The following is a description of a gene set: from publication Chen Y, Wang X (PMID 31504780) Human Gene Set: MIR3184_3P species: Homo sapiens Genes predicted to be targets of miRBase v22 microRNA hsa-miR-3184-3p in miRDB v6.0 with MirTarget v4 prediction scores > 80 (high confidence targets)., and this is the list of marker genes: CREB1, FBXO11, PWP2, TAL1, CTDSPL2, EGR1, COL17A1, NLK, KLHL15, RBBP5, POLR3G, NBEA, GALNT16, CDY1, ZNF682, IKZF4, F2R, CEP15, TEAD1 (TEA domain transcription factor 1), ADCYAP1R1, ACADSB (NCBI Gene Id 654185), LRIG1, ROR1, SMAD2, BMS1, KIF3A, TEF, TOR1AIP2, SLITRK3, SLC30A4, RAP2C, GCH1, IRAK4, ETNPPL, PAM, CDY1B, FUT8, CA10, RAB5A, LIPA, TAOK1, CD4, AFF4, ZFY, CPPED1, ZFHX4, ITCH, NCOR1, BPNT2, PANK2, ANKIB1, ID1, RXRG, SETD9, GTF2A2, NHSL1, BACE2, RAB3GAP2, MCFD2, MAPK9, GGNBP2, MBOAT2, FAM199X, MAN2A2, ZBTB44, SIK2, DIO2, PPM1A, KLHL8 (NCBI Gene Id 57563), RIMKLB, CKB, SCOC, POMGNT1, CHIC2, GRIA4, CLASP1